The following is a description of a gene set: part of: SLC transporter disorders Members of the SLC2A family encode glucose transporter (GLUT) proteins that mediate the facilitated diffusion of glucose between the extracellular space and the cytosol. While the monomeric protein can form a channel and transport glucose, kinetic studies suggest that the functional form of the protein is a homotetramer. SLC2A1 (GLUT1) is expressed by many cell types, notably endothelial cells, red blood cells and cells of the brain. Its low Km for glucose (~1 mM) relative to normal blood glucose concentration (~5 mM) allows these cells to take up glucose independent of changes in blood glucose levels. Defects in SLC2A1 can cause neurological disorders with wide phenotypic variability. The most severe 'classic' phenotype, GLUT1 deficiency syndrome 1 (GLUT1DS1; MIM:606777), comprises infantile-onset epileptic encephalopathy associated with delayed development, acquired microcephaly, motor incoordination and spasticity. Reactome Pathway: Defective SLC2A1 causes GLUT1 deficiency syndrome 1 (GLUT1DS1) studied in species Homo sapiens, and this is the list of marker genes: SLC2A1 (NCBI Gene Id 6513)